Given this list of marker genes GPR180, ETAA1, ARHGEF25, OXA1L, HES4, PGM3, MFSD4B, KAZALD1, ITCH, SSU72, INTS2, ZNF488, EIF2B3, C19orf12, UFSP2, GET4, EIF3H, P4HA2, PLCD3 (NCBI Gene Id 50520), LMAN2L, ERG28, PARL, DBR1, RPTOR, TELO2, TIMM23B, PLAUR, TIGD6, SMC1A, TRIM59, IQGAP2, ZNF90, ECD, SRP9, POLR3K, RAB11A, RIC8A, CHST2, ZNHIT3, GIGYF2, DDX20, NIT1, MLF2, VRK1, PFKL, CDKN2AIP, PTRHD1, PPP2R3C, NOP16, TRRAP, EIF3A, PI4KA, SNX10, ATF7IP, AP1B1, GRAP2, BET1L (Bet1 golgi vesicular membrane trafficking protein like), IFNGR2, IFT46, ATP5ME, ATL3, TFE3, PBX1, LMNA, PLOD1, SRP72, ORC2, GOLPH3, H4C3, HSPA9, MRPS34 (NCBI Gene Id 65993), FZR1, CTAG2, ELF4, ZNF676, GRHL1, SHARPIN, VAMP3, RFC1 (replication factor C subunit 1), MOB4, LIN9, GPATCH3, INTS3, RRP9, PTPRH, GFER, CELF1, SLC39A9, FOXD1, JAGN1, MEA1, HACE1, TUBD1, POPDC3, ZNF41, MYBBP1A, TACO1, DENND4C, FOXK1, SERPINH1, WDR75 (NCBI Gene Id 84128), TAF6, NDUFAB1, PIP5K1C, GEMIN5, PEX2, DHX34, GPD1L, MRPL41, PSMD7, FTSJ1, OR7A10, SPAG7, WDR26, POP4, SELENOM, EXOC5, EMP2, NCL, POLR3D, PTCD2, BPGM, KRT18 (keratin 18), DCAF5, TRMT11, RNF207, TKT, RPS6, HOXB9 (NCBI Gene Id 3219), CLCC1, TDRKH, SAMM50, ENTPD6, CIAPIN1, EIF2B1, PRSS16, TGIF2LX, TBL3, ZCCHC17, TM9SF3, POLR3C, TPR, WDR77, CENPP, AP2S1 (NCBI Gene Id 9161), SSBP1, EXOSC9, EIF2B5, DNAJA3, C2orf76, BTAF1, MRTO4, COMMD9, LARP4B, CARHSP1, NDUFC1, PHOSPHO2, RPP14, COG4, SSBP4, YBX2, NUFIP1, PKLR, SPTY2D1, PMF1, ZNF519, EXOC4, LSM11, GCSH, STYXL1, POLR3G, HYLS1 (HYLS1 centriolar and ciliogenesis associated), CLDND1, CIAO2B, RINT1, ZDHHC19, SRSF11, COG7, ZNF654, CEP57, C17orf58, STARD10, DERL3, SS18L2, PHB1 (prohibitin 1), RRAS2, SRXN1, MED12, ZNF587, TRPS1, CACYBP, ZDHHC4, HECTD1, CEP72, COPB2, LANCL1, HSPA14, USP30, BTG3, PBRM1, ZNF157, SEC24C, C1orf174, MIER1, ATRIP, SFPQ, SNAPC1, PSMC2, INO80B, POC1A, ACOX1, SNX17, HIKESHI, RNF145, GTPBP3, MBOAT2, SLC11A2, SLC40A1, EEFSEC, ZNF33A, ARL14EP, USP15, LRPPRC, ARHGAP18, MECOM, SUPT6H, PHB2, DDX55, UQCR10, MOSMO, GDPD5, ENOPH1, MED10, WDR83OS, TTI1, FUNDC2, ZNF536, ERMAP (NCBI Gene Id 6306), ZNF518B, GRPEL1, MRPL24, AATF, EIF1AX, TMT1A, PAX9, BAIAP2L1, UQCRQ, ESYT2, UBA6, ECPAS, NEURL4, UBE2D3, HNRNPUL2, UTP23, ITM2A, RANBP9, ABHD8, RBM18, INF2, ENPP3, LSG1, NETO2, ANKMY2, YES1, MCTS1, CDK2AP2, ZNF607, SIVA1, MRPS22, HOMER1, CHMP6, CCDC144A, HEXIM2, WDR3, DHRSX, TNFRSF10A, HSD17B12, NR0B1, TBX21, RBM19, SACM1L, MRPL46, MARS1, MED19, AHSP, EGLN2, ZNF414, PDLIM7, TMEM14B, RHD, HYCC2, TIMM44, TRAPPC11, KLF4, MRPL37, IPPK, ZNF528, TTC27, NDUFB1, DDX21, DOK1, FOXN4, TUBGCP6, ZNF514 (NCBI Gene Id 84874), POLR1D, PDRG1, TRMT12, CES2, YWHAE, PPFIA3, FAM117A, TMEM68, ALG11, DDX39B, FAM89B, MRPL39, SEPTIN6 (septin 6), NAA15, CEBPG, TPST2, HECTD4, NMU, FHL2, STT3B (NCBI Gene Id 201595), BAZ2A, EXOSC2, HSPH1, SPIB, DNASE1L1, ZBTB17, CNOT10, BARX1, HOXB3, RIF1, GLI3, ZNF749, PHF7, DKC1, TAF13, SEC61A1, PHOX2A, PRPF8, SPART, RPP30, ALMS1, NUDT15, HLA-B, ROMO1, ZNF565, CCNA2, CYSTM1, RECQL5, CLU, PLPBP, TRPC4AP, AEN, COMMD8, SLC25A14, CPD, SFXN2, CYBA, SEPTIN8, HEATR1, SSR3, DYNLT3, NDUFB8, KAT7, ABHD11, GOLM1, TUBB2B (tubulin beta 2B class IIb), SOD1, EXOSC8, IPO13, CHPT1, LTF, TSR2, ICAM1, FBXO3, NAA25, DHDDS, DOHH, BLOC1S3 (biogenesis of lysosomal organelles complex 1 subunit 3), CBY1, PRPS2, CFLAR, NUP160, NCOA5, GRB10, BCL6B, CIP2A, SRP68, C3orf38, LITAF, ERF, GFM1, STAT5B, RAP1GAP, RNF13, UTRN, PAICS, MRPS35 (mitochondrial ribosomal protein S35), CCDC116, NSRP1 (nuclear speckle splicing regulatory protein 1), PSMG4, VAX2, NDUFB3, MORN1, NDUFB9, FRA10AC1, CMTM4, COX11, RBM4, DPF1, JPT1, NUDT4 (nudix hydrolase 4), CMC4, RMND1, OR4N2, KIFC1, ANXA1, FKBP9, NACA, DCP1A, RICTOR, SLC35E1, LGALSL, SLC35G2, MAGEA9B, RRS1, AAR2, ATP2B4, PCMT1, PRDM16, SNRNP40 (small nuclear ribonucleoprotein U5 subunit 40), DRG2, GSTO1, TENT4A, PTCD1 (pentatricopeptide repeat domain 1), VPS26B, DERL1, ATG16L1, WAC, CPNE1, TMEM39B, CCND3, MOB2, ZSCAN20, ATF2, ZNF827, PET100, RAD21, KCTD13, BABAM1, GJA3, CHIC2, RNF26, PIGK, CCAR1, SS18, REX1BD, ZRANB2, CTSF, CXorf38, POM121C, ATP6V0D1 (NCBI Gene Id 9114), ABCC10, EPAS1, FARSB, ZNF154, MBD1, OTUD7B, MRPS12, CARD11, RAB3IP, NELFE, TOMM22, TMEM258, STXBP4, ENSA, IMMT, TTC33, PSMD13, RNF123, TRIM25, PAQR4, NDUFB2, XPO1, GM2A, CYCS, POLR3B (NCBI Gene Id 55703), HSPBP1, FOXI3, DUS1L, ICE1, ZFYVE16 (NCBI Gene Id 9765), CEP164, STXBP3, QTRT2, ETV4, MRE11, GLRX5, NSMCE1, INTS8, TEC, FDX2, SNX24, TRMT112, ZNF683 (NCBI Gene Id 257101), RNF208, ATP5F1C, CEP55, RIOX2, DHX57, POLG2, MED30, METRNL, SLC25A16, LONP1, S100A6 (NCBI Gene Id 6277), TMEM135, GADD45GIP1, WSB1, MSH5, SDR39U1, EIF4E, UNK, EHD4, TRMT10C, USP40, TTC14 (tetratricopeptide repeat domain 14), GRHL3, TBRG4, GET3, SPTBN1, PRMT3, here is a description of the gene set: studied in species Homo sapiens Transcription regulation during the cell cycle is crucial for ensuring genes are expressed at the right time and in the correct amounts, coordinating key processes like DNA replication, mitosis, and cell division. In our study, Genes whose depletion leads to accumulation of cells in G2/M (pVal < 0.05) in K562 Repogle et al., 2022 reanalyzed with Velocycle from Lederer et al., 2024 Human Gene Set: PULVER_FOREY_PERTURB_ATTRITION_G2_M